The following is a description of a gene set: studied in species Mus musculus Any process that stops, prevents or reduces the frequency, rate or extent of leukocyte cell-cell adhesion. Mouse Gene Set: GOBP_NEGATIVE_REGULATION_OF_LEUKOCYTE_CELL_CELL_ADHESION, and this is the list of marker genes: Pten, Cd80, Lrrc32, Gli3, Rc3h1, Pla2g5, Rc3h2, Socs1, Il20rb, Tgfb1 (transforming growth factor, beta 1), Pla2g2a (NCBI Gene Id 18780), Gnrh1, Il4i1 (NCBI Gene Id 15088), Pdcd1lg2 (programmed cell death 1 ligand 2), Slc4a2 (NCBI Gene Id 20535), Zfp35, Ihh, Nfkbid, Tmem131l, Pawr, Shh, Pdcd1, Ccl21e, Prdx2, Cdkn2a, Socs5, Itch, Ccl21b, Ccl21a, Cd86, Lax1 (lymphocyte transmembrane adaptor 1), Fgl1, Btla, Lilrb4a, Akt1, Cbfb, Cd44, H2-M3, Cd276, Glmn, Tsc2, Twsg1, Anxa1, Tspan32, Ildr2, Casp3, Ccl28, Loxl3, Zc3h12d, Pde5a, Scrib, Cebpb (NCBI Gene Id 18031), Mad1l1, Dlg5, Ndfip1, Dapl1, Jak3, Tnfsf4, Havcr2, Spn, Bmp4, Smad7, Tnfsf18, Ptpn22, Pla2g2d, Hlx, Cd69, Peli1, Adtrp (androgen dependent TFPI regulating protein), Sftpd, Crtam, Lilrb4b, Il4, Pf4, Prnp, Erbb2 (erb-b2 receptor tyrosine kinase 2), Gimap3, Cblb, Sdc4, Hspb1, Tbx21, Ccl21d, Il2ra, Pag1, Scgb1a1, Bcl6, Ceacam1, Lgals9, Cxcl12, Cd74, Lgals3, Cd37, Mia3 (MIA SH3 domain ER export factor 3), Il4ra, Pla2g2f, Ido1, Irf1, Arg1, Il2 (NCBI Gene Id 16183), Ccl21f, Cd300a, Ccl25, Tnfrsf14, Gpnmb, Tigit, Vsig4, Ctsg, Gstp1, Ppara, Slfn1, Zfp608, Dlg1, Socs6, Ripor2, Ptpn6, Ifnb1, Wnk1, Ascl2, Vsir, Foxj1, Btn2a2, Clec4g, Lag3, Zc3h8, Vtcn1, Tnfrsf21, Tnfaip8l2, Nrarp, Arg2, Lgals1, Ptpn2, Runx1, Dtx1, Gimap5, Laptm5, Xcl1, Hmgb1, Foxp3, Hfe, Klf4, Ufl1, H2-Aa, Rag2, Fgl2, Prkar1a, H2-T23, Runx3, Marchf7, Adora2a, Cd24a, Mdk, Ctla4, Cd274, Tarm1, Adam8, Ass1, Zbtb7b, Zc3h12a, Dusp22, Dusp3